The following is a description of a gene set: Hemangiomatosis studied in species Homo sapiens Human Gene Set: HP_HEMANGIOMATOSIS, and this is the list of marker genes: PTH1R, TEK, CAPNS1, ACVRL1, PTEN, FGFR2 (fibroblast growth factor receptor 2), ENG, GNAQ, SLC26A2, AKT1, KRAS, PIK3CA, SMAD4, FGFR1, IDH2, IDH1, VHL, EIF2AK4, RASA1, CCND1, GDF2